The following is a description of a gene set: Reactome Pathway: Mitochondrial Uncoupling part of: Aerobic respiration and respiratory electron transport This event has been computationally inferred from an event that has been demonstrated in another species.<p>The inference is based on the homology mapping from PANTHER. Briefly, reactions for which all involved PhysicalEntities (in input, output and catalyst) have a mapped orthologue/paralogue (for complexes at least 75% of components must have a mapping) are inferred to the other species. species: Mus musculus electronically inferred by orthology from the curated human pathway, and this is the list of marker genes: Slc25a14, Ucp3, Ucp2, Slc25a4, Ucp1